Given this list of marker genes Tdg, Mbd4, Neil1, Ogg1, Nthl1, Neil2, here is a description of the gene set: This event has been computationally inferred from an event that has been demonstrated in another species.<p>The inference is based on the homology mapping from PANTHER. Briefly, reactions for which all involved PhysicalEntities (in input, output and catalyst) have a mapped orthologue/paralogue (for complexes at least 75% of components must have a mapping) are inferred to the other species. part of: Base-Excision Repair, AP Site Formation species: Mus musculus Reactome Pathway: Depyrimidination electronically inferred by orthology from the curated human pathway